The following is a description of a gene set: MAPK cascade studied in species Homo sapiens Human Gene Set: WP_MAPK_CASCADE, and this is the list of marker genes: MAP3K12, NRAS, PLCB3, MBP, JUN, SOS2, KRAS, SOS1, MAPK3, ARAF, RAF1, MAP2K2, MAPK12 (NCBI Gene Id 6300), MAP2, RRAS, MAP2K7 (mitogen-activated protein kinase kinase 7), RASA3, LAMTOR3, MAPK1, HRAS, MAP2K1, MAPK14, GRB2, MAP3K2, MAP2K6, MAP2K4, MAPK10, MAP2K3, SIPA1, MAP3K3, ELK1, BRAF, MAP3K1